Given this list of marker genes SHOC2, PPP1R12A, TOX4, PPP1R15A, PPP1R3C, NCK1, PPP1R10, MRAS, PPP1R3E, PPP1R9B (NCBI Gene Id 84687), PPP1R3A, PPP1CA, PPP1R3G, PPP1CB, PPP1R3F, PPP1R15B, PPP1R3B, PPP1CC, PPP1R3D, WDR82, here is a description of the gene set: A protein complex that possesses magnesium-dependent protein serine/threonine phosphatase (AMD phosphatase) activity, and consists of a catalytic subunit and one or more regulatory subunits that dictates the phosphatase's substrate specificity, function, and activity. studied in species Homo sapiens Human Gene Set: GOCC_PROTEIN_PHOSPHATASE_TYPE_1_COMPLEX